The following is a description of a gene set: Mitotic G2-G2/M phases Mouse Gene Set: REACTOME_MITOTIC_G2_G2_M_PHASES studied in species Mus musculus, and this is the list of marker genes: Lcmt1, Csnk1e, Ppme1, Csnk1d, Rps27a, Uba52, Ywhae, Obi1, Tubg1, Cdk11b, Hsp90ab1, Ppp1r12a, Psmd6, Ajuba, Psmb6, Tuba4a, Fzr1, Ccna1, Cep70, Cep41, Dctn3 (dynactin 3), Psmd1, Tuba3b, Tubgcp2, Cenpj, Ccnh, Ticrr, Tubg2, Dctn2, Psma1, Rbx1, Nedd1, Ppp1r12b, Sfi1, Cep164, Psma7, Psmd7, Psmb7, Pafah1b1, Tuba1a, Tubb4b, Phlda1, Gtse1, Ofd1, Cep76, Tubb3, Mzt2, Haus8 (4HAUS augmin-like complex, subunit 8), Psmb4, Dynll1, Ppp2cb, E2f1, Ccna2, Cep192, Ppp2ca (protein phosphatase 2 (formerly 2A), catalytic subunit, alpha isoform), Actr1a, Ninl, Tubgcp4 (NCBI Gene Id 74395), Trp53, Ccnb2, Uba52rt, Dync1i2, Psmd11, Psmb1, Hsp90aa1, Psmd8, Fbxw11, Psma4, Tuba3a, Psma3, Psmc1, Ppp2r1b, Ckap5, Cdc25b, Fbxl7 (NCBI Gene Id 448987), Psmb3, Ppp1cb, Wee1, Fkbpl (FK506 binding protein-like), Nde1, Adrm1, Tubb2b, Cul1, Foxm1, Ubc, Pcm1, E2f3, Psmd13, Aurka, Pkmyt1, Cep57, Tubal3, Haus6 (HAUS augmin-like complex, subunit 6), Nme7, Tubgcp6, Psmb5, Tuba1c, Sgo1, Cetn2, Dctn1, Psmd2, Mapre1, Cep43, Cep135, Bora, Tubgcp5, Tuba1b, Akap9, Cep131, Ywhag, Psmc5, Psmb2, Ppp2r1a, Plk1, Tubb1, Psmd14, Psma5, Ssna1, Ppp2r2a, Cdk7, Psmd3, Haus7, Tubb5, Psmc3, Hjurp, Cep290, Cdk5rap2, Cep152, Nek2 (NIMA (never in mitosis gene a)-related expressed kinase 2), Plk4, Clasp1, Haus1, Tubb4a, Cdk1 (NCBI Gene Id 12534), Cep250, Mzt1, Ppp2r3d, Skp1, Hmmr, Psmc2, Cdc25a, Optn, Haus3, Prkaca, Tubgcp3, Cep63, Mis18bp1, Sdccag8, Alms1, Tuba8, Psma2, Rab8a, Odf2, Dync1h1, Cdkn1a, Tubb6, Ubb, Haus5, Cep72, Ccnb1, Cdc25c, Ccp110, Cep78, Psmc6, Psmc4, Xpo1, Haus2, Haus4, Psma6, Mnat1 (menage a trois 1), Fbxl18, Psmd12, Cdk2, Tpx2, Tubb2a